The following is a description of a gene set: studied in species Homo sapiens Acyl chain remodeling of triacylglycerol (TAG) and diacylglycerol (DAG) progresses through their hydrolysis by patatin-like phospholipase domain-containing proteins 2/3 (PNPLA2/3). DAG is reacylated back to TAG by acylglycerol O-acyltransferase 1/2 (DGAT1/2), while DAG and its hydrolysis product 2-monoacylglycerol (2-MAG) are transacylated back to TAG by PNPLA2/3. In addition, the DAG hydrolysis product 2-MAG is subsequently hydrolyzed to fatty acid and glycerol by monoglyceride lipase (MGLL). part of: Glycerophospholipid biosynthesis Reactome Pathway: Acyl chain remodeling of DAG and TAG, and this is the list of marker genes: PNPLA2, AWAT2, DGAT2L6, DGAT1, MGLL, PNPLA3, DGAT2